The following is a description of a gene set: Mouse Gene Set: CUI_NK_CELL_41BBL_RESPONSE_UP studied in species Mus musculus from publication Cui A, Huang T, Li S, Ma A, Pérez JL, Sander C, Keskin DB, Wu CJ, Fraenkel E, Hacohen N (PMID 38057668) Genes positively differentially expressed in cell type: NK cell upon treatment with cytokine: 4-1BBL in mouse lymph nodes in vivo. Cytokines mediate cell-cell communication in the immune system and represent important therapeutic targets. A myriad of studies have highlighted their central role in immune function, yet we lack a global view of the cellular responses of each immune cell type to each cytokine. To address this gap, the authors created the Immune Dictionary, a compendium of single-cell transcriptomic profiles of more than 17 immune cell types in response to each of 86 cytokines (>1,400 cytokine-cell type combinations) in mouse lymph nodes in vivo. A cytokine-centric view of the dictionary revealed that most cytokines induce highly cell-type-specific responses. For example, the inflammatory cytokine interleukin-1β induces distinct gene programmes in almost every cell type. A cell-type-centric view of the dictionary identified more than 66 cytokine-driven cellular polarization states across immune cell types, including previously uncharacterized states such as an interleukin-18-induced polyfunctional natural killer cell state., and this is the list of marker genes: Calr, Dkc1, Aph1a, Pdia3, Cacybp, Tma16, Arf1, Rpf2, Pwp1, Gdi2, Cycs (NCBI Gene Id 13063), Cmip, Tubb4b, Nars1, Pfn1, Hars1, Erh, Myl12a, Prmt7, Mrpl16, Cotl1, Srsf2, Lfng, Cmpk1